Given this list of marker genes DYNLL1, PDX1, SYBU, OXCT1, JAGN1, SLC9B2, UCP2, RAB11FIP5, TUNAR, RFX6, PDE8B, KCNK16, PIM3, TRPM4, VSNL1, C2CD2L, MLXIPL, ADCY5, HIF1A, FOXA2, ADCY8, CCDC186, NR1D1, C1QTNF12, ADRA2A, GHRL, BAIAP3, TRPM5, BRSK2, RAC1, CRH, ENY2, SELENOT, SRI, MPC2, KLF7, GPRC6A, PPP3CB, STX4, BAD, HLA-DRB1, GPR68, GPR27, NR1H4, RAB11FIP2, RAB11B, PHPT1, ZBED6, EPHA5, SLC2A2, CLTRN, PRKCE, PTPRN, CDK16, GCG, LRP5, PTPRN2, STXBP4, FKBP1B, NADK, SIDT2 (NCBI Gene Id 51092), NDUFAF2 (NCBI Gene Id 91942), CFTR, ANO1, PLA2G6, RBM4, ABCA12, GPLD1, ABCC8, EFNA5, PRKN, OSBP, RAF1, PPARD, TRPA1, here is a description of the gene set: Human Gene Set: GOBP_INSULIN_SECRETION_INVOLVED_IN_CELLULAR_RESPONSE_TO_GLUCOSE_STIMULUS The regulated release of proinsulin from secretory granules (B granules) in the B cells of the pancreas; accompanied by cleavage of proinsulin to form mature insulin, in response to a glucose stimulus. studied in species Homo sapiens